The following is a description of a gene set: Reactions triggered in response to the presence of a bacterium that act to protect the cell or organism. studied in species Homo sapiens Human Gene Set: GOBP_DEFENSE_RESPONSE_TO_BACTERIUM, and this is the list of marker genes: PYCARD, GSDMA, IL23A, ZNFX1, CD4, OAS3, DEFB107B, CCL20, MBL2, LYG2, SPON2, RPL30, DEFB130A, MMP7, LACRT, AICDA, DEFB112, TNFSF8, DEFB1, WFDC13, SPN, DCD, IL18, DEFB131B, KLRK1, SPRR2A, XIAP, H2BC12L, RASGRP4, CASP1, NAGK, HAMP, DEFA1B, STATH, IGHE, IL1B, LYZL6, IL6R, SLPI, CRP, ADGRB1, DEFB136, IRGM, RNASE9, SPAG11A, CST11, DEFA6, DHX15, IGHG3, RAB14, PGLYRP3, WFDC10A, DEFB114, NFKB1, SHC1, DEFB134, S100A12, IL23R, ELANE, STAB1, NOS2, COLEC12, RBPJ, APP, GBP1, MR1, IGHA2, HLA-A, SCNN1B, NLRP10, PGLYRP2, DEFB103B, SHARPIN, SLAMF8, SPINK5, ANKRD17 (NCBI Gene Id 84177), CASP4, ARG2, ANG, B2M, KLRC4-KLRK1, PGC, TAB2, LCN2, DEFB132, VIP, DEFB103A, ROMO1, DEFB133, MIR140, H2BC11, MICA, IKBKG, NFKBIZ, DEFB115, H2BC21, S100A14, FCER2, RNASE7, ADAMTS5, DEFA5, MYD88, DEFB106B, RNASE4, TLR6, SLC30A1 (NCBI Gene Id 7779), NOD2, GBP5, H2BC6, IL27RA, HCK, MPO (myeloperoxidase), WFDC12 (NCBI Gene Id 128488), GNLY, DEFB106A, LYG1, DEFB116, MARCHF2 (NCBI Gene Id 51257, membrane associated ring-CH-type finger 2), DEFA1, NOD1, RNASE2, RNASE1, SEMG2, RNASE8, WFDC9, GBP6, DAO, NLRP1, HTN1, GSDMB, RNASE11, RBCK1, IGHG1, NCF1, TRAV27 (NCBI Gene Id 28655), RIPK2, JCHAIN, TNFRSF1A, TIRAP, ISG15, DEFB126 (defensin beta 126), MIR181B1, TF, IGHA1, WFDC3 (WAP four-disulfide core domain 3), FGB, HAVCR2, DEFB119, GBP7, RAB1A (RAB1A, member RAS oncogene family), DEFB121, S100A9, LTF, MAPKBP1, EMILIN1, LYPD8, EPX, OAS2, DEFB107A, DEFB130B, LGALS4, CHGA, FGR, CLEC4D, SYT11, LALBA, TNF, IRF8, TSLP, BPI, UMOD, LPO, PLA2G1B, BPIFA1, TNFRSF14, PGLYRP1, SPAG11B, CYBA, LTA, RARRES2, VGF, IGHM, SLC15A2, S100A8, CLEC4E, TLR9, C5AR1, CALCA, H2BC10, ADAMTS4, DEFB131A, LYZL4, WFDC10B, PPP1R11, PCYOX1L, DEFB110, CXCL13, BCL3, CFP, PRG2, NLRP6, WFDC5, RNASE12, TUSC2, MIR223, EMILIN2, DEFB129, EVPL, FGA, RAG2, CD160, CARD9, PRKCD, ADM, PRB3, FOXP1, NOTCH2, LEAP2, HMGB2, DEFB118, NR1H4, PLAC8, IL7R, SERPINE1, DEFA3, MIRLET7B, TLR3, TLR4, HTN3 (histatin 3), LYST, AKIRIN2, NLRC4, ACP5, TBK1, RPS19, NAIP, STAB2, HLA-E, DMBT1, H2BC7, PPBP, TFEB, IL22RA1, RNASE10, LBP, DEFB104B, EPHA2, MPEG1, RNASE6, CXCL6, SYK, GBP2, DEFB113, SEMG1, WFDC11, GRN, IL17F, RPL39, H2BC8, AZU1, IGKV3-20, FPR2, DEFB108B, OPTN, DEFB128, DEFB127, LYZ, SFTPD, SELP, LCE3A, TAC1, GALP, WFDC2, SEH1L (NCBI Gene Id 81929), IFNE, REG3G, ADAM17 (ADAM metallopeptidase domain 17), PGLYRP4, DEFB124, F2, FCGR1A, CD36, GSDMC, FCER1G, P2RX7, DEFB104A, TAB3, DEFB109B, FCN2, DEFB105B (NCBI Gene Id 504180), CASP7, PRKD1, GBP4, DEFB125, TREM1, IGHG2, IL33, GBP3, MMRN2, FAU, ZG16, IL12B, NPY, RNASE3 (NCBI Gene Id 6037), HP, CAMP, DEFB105A, CTSG, TLR2, LCE3B, GSDMD, MAVS, EPPIN, OAS1, KLK7, SIGLEC16, AQP1, IGHG4, GPR15LG, RNASE13, KRT6A, CEBPB, DEFB123 (NCBI Gene Id 245936), IL10, IL6, MAP3K7, RNF31, PLA2G6, ANXA3, KLK5, DEFB135, F2RL1, DEFB108A, PLA2G2A, RNF213, DEFA4, TMF1, KLK3, BPIFA2, DEFB4A, IGHD, H2BC12, IL12A, PI3, LCE3C, SLC11A1, IL17A, H2BC4, TREM2, SLC9A9, SSC5D, DROSHA